The following is a description of a gene set: Up-regulated in murine dorsal skin cells at 6 h after treatment with the phorbol ester carcinogen TPA. studied in species Mus musculus Mouse Gene Set: SCHLINGEMANN_SKIN_CARCINOGENESIS_TPA_UP Malignant transformation of mouse skin by chemical carcinogens and tumour promoters, such as the phorbol ester 12-O-tetradecanoylphorbol-13-acetate (TPA), is a multistage process that leads to squamous cell carcinoma (SCC) formation. In an effort to identify tumour-associated genes, we studied the influence of short-term TPA-treatment on the gene expression profile of murine skin. A comprehensive microarray with some 5,000 murine gene specific cDNA fragments was established and hybridised with pooled RNA derived from control and TPA-treated dorsal skin samples. Of these genes, 54 were up- and 35 were down-regulated upon TPA application. Additionally, we performed suppression subtractive hybridisation (SSH) with respective RNA pools to generate and analyse a cDNA library enriched for TPA-inducible genes. Expression data of selected genes were confirmed by quantitative real-time PCR and Northern blot analysis. Comparison of microarray and SSH data revealed that 26% of up-regulated genes identified by expression profiling matched with those present in the SSH library. Besides numerous known genes, we identified a large set of unknown cDNAs that represent previously unrecognised TPA-regulated genes in murine skin with potential function in tumour promotion. Additionally, some TPA-induced genes, such as Sprr1A, Saa3, JunB, Il4ralpha, Gp38, RalGDS and Slpi exhibit high basal level in advanced stages of skin carcinogenesis, suggesting that at least a subgroup of the identified TPA-regulated genes may contribute to tumour progression and metastasis. from publication Schlingemann J, Hess J, Wrobel G, Breitenbach U, Gebhardt C, Steinlein P, Kramer H, Fürstenberger G, Hahn M, Angel P, Lichter P (PMID 12640676), and this is the list of marker genes: Pdpn, Fbxl9, Kbtbd11, Bop1, S100a9, AI507597, Srm, Sprr2a1, Scgb1a1, Trnt1, Tmco5, Mat2a (methionine adenosyltransferase 2A), Stk35, Edf1, Nabp1, Creb3, Fbxw18 (F-box and WD-40 domain protein 18), Anxa6 (NCBI Gene Id 11749), Selenos, Sprr1a, Junb (NCBI Gene Id 16477), Mt1, H2al1m, Krt88, Ptbp1, Gch1, Mt2, Bpifa1, Nme1, Crnkl1, Ralgds, Plbd1, Ctsl, Rbm6, Adar, Slpi, S100a8, Rrad, Rorb, Tnfrsf18, Lsm8 (LSM8 homolog, U6 small nuclear RNA associated), Odc1